Given this list of marker genes Lonp2, Acot2, Baat, Ubb, Hao1, Pex7, Pex13 (NCBI Gene Id 72129), Acot3, Ube2d1, Hsd17b4, Ehhadh, Acox3, Rps27a, Acot4 (acyl-CoA thioesterase 4), Decr2, Acot5, Acaa1b (NCBI Gene Id 235674), Ephx2, Pex1, Tysnd1, Nos2, Mlycd, Acot8, Crot, Acox2, Amacr, Dhrs4, Ech1, Mpv17, Pex5, Slc27a2, Pex12, Pipox, Eci2, Pex26, Dao, here is a description of the gene set: electronically inferred by orthology from the curated human pathway species: Mus musculus This event has been computationally inferred from an event that has been demonstrated in another species.<p>The inference is based on the homology mapping from PANTHER. Briefly, reactions for which all involved PhysicalEntities (in input, output and catalyst) have a mapped orthologue/paralogue (for complexes at least 75% of components must have a mapping) are inferred to the other species. Reactome Pathway: Peroxisomal protein import part of: Protein localization